The following is a description of a gene set: species: Homo sapiens Human Gene Set: chr3q25, and this is the list of marker genes: KCNAB1, TM4SF18, KCNAB1-AS2, PLCH1, ARHGEF26, TM4SF18-AS1, AADAC, RPS25P5, ENSG00000271922, P2RY13, SHOX2, VEPH1, CRADDP1, ATP5MGP5, MRE11P1, LINC01214, MIR15B, IFT80, ARHGEF26-AS1, SERP1, RPL6P7, DTWD1P2, SAP30P1, SIAH2-AS1, B3GAT3P1, DYNLL1P5, KPNA4, PABPC1P10, RPL32P9, IL12A, EIF3JP2, GMPS, GPR171, SYPL1P1, PPM1L, ALG1L15P, RPL7AP24, WWTR1, IQCJ-SCHIP1, ENSG00000243273, ENSG00000201398, MIR3919, RN7SKP177, RNU7-136P, LEKR1, RN7SKP46, MFSD1, CP, TIPARP, ENSG00000288787, P2RY12, LINC02877, GPR149, CPHL1P, GPR87, PPIAP73, LINC01100, P2RY14, LXN, WWTR1-AS1, SIAH2, LINC01998, PPM1L-DT, RPS12P7, LINC03109, AADACL2-AS1, TSC22D2, SNRPCP3, PA2G4P4, ANKUB1, SLC33A1, EIF2A, RN7SL300P, RN7SL715P, MIR16-2, SNORA72, PLCH1-AS1, LINC02066, C3orf33, KRT8P12, LINC01213, TRIM59-IFT80, RNF13, ERICH6, MLF1, PCBP2P4, METTL15P1, CLRN1, RNU6-720P, RNA5SP146, RPL15P6, MTAPP1, COMMD2, PLCH1-AS2, WWTR1-IT1 (NCBI Gene Id 106478977), RAP2B, SMC4, KIAA1328P1, AADACL2, RARRES1, TM4SF4, RNU6-507P, LINC00881, MINDY4B (NCBI Gene Id 651844), RFKP6, HNRNPA1P24, ENSG00000243953, LINC01487, RPL21P42, SCHIP1, SCARNA7, TIPARP-AS1, LINC02006, PFN2, P2RY1, NPM1P29, PFN2-AS1, RNU6-1098P, LINC00880, SSR3, MIR5186, ENSG00000286585, WDR70P1, RNU2-31P, FKBP1AP4, DHX36, AADACP1, SUCNR1, RPL9P15, ARL14, MME, MLF1-DT, RPL35AP9, LINC02029 (NCBI Gene Id 105374177), MED12L, PTX3, STRIT1, GPR79, SLC66A1LP, ENSG00000240207, ENSG00000287706, MME-AS1, CCNL1, KCNAB1-AS1, TMEM14EP, RPL6P8, HMGN2P13, DDX50P2, IL12A-AS1, IGSF10, ERICH6-AS1, C9orf78P1, RNU6-901P, TMEM183BP, MBNL1-AS1, TM4SF1-AS1, RPL35AP10 (ribosomal protein L35a pseudogene 10), RSRC1, MBNL1 (muscleblind like splicing regulator 1), C3orf80, TM4SF1, SETP14, EEF1A1P45, SETP11, LINC02917, SELENOT, ENSG00000287688, BRD7P2, IQCJ-SCHIP1-AS1, RPS2P19, RPL32P8, TRIM59, GFM1, RNA5SP145, MRPL42P6, VN2R1P, IQCJ, LILRA2P1, KRT18P34, KLF3P2, SNRNP40P1